The following is a description of a gene set: Genes containing one or more binding sites for (Nr2f2) in their promoter regions (TSS -1000,+100 bp) as identified by GTRD version 20.06 ChIP-seq harmonization. Mouse Gene Set: NR2F2_TARGET_GENES studied in species Mus musculus from publication Yevshin I, Sharipov R, Kolmykov S, Kondrakhin Y, Kolpakov F (PMID 30445619), and this is the list of marker genes: Ankrd39, 3110031N09Rik, Med16, Tmem259, Eprs1, Ascc2, Gm15722, Ak1 (NCBI Gene Id 59018), Qtrt2, 4921504E06Rik, Pum3, Phactr2, Ube2g2, Tnni3, Uck1, Arcn1, Desi1, Mtx3, Atf1, Manba, Mmgt2, Josd1, Zfp827, Dnajc19, Gm11483, Cep120, Hikeshi (NCBI Gene Id 67669), Upf3b, Hmgxb3, Ndufa2, Pex11g, Tbx3os1, Toe1, Socs5 (NCBI Gene Id 69052), Pspc1 (NCBI Gene Id 66645), Sdha, Zpr1, Podxl, Dennd4b, Six1, Tecrl, Ganab, Gm11214, Tti1, Adcy6, Smc5, Gm24016, Ccdc191, Mpc2, Pgm5 (phosphoglucomutase 5), Ccn2, Ogfrl1, Dusp28, Etfa, Alkbh7, Cluh, Baz1b, Ptp4a3, Xrcc6, Akt1s1, Zfp62, Hspe1, Susd6, Maip1, Prkce, Srp72, Rgl1, Elf4, Fhl1, Pphln1-ps1, Dtx4, Etohd2, 0610031O16Rik, Tor3a, Zfpm1, Tent2, Tmem198, Agps, 4930532G15Rik, Homer3 (NCBI Gene Id 26558), Zfand2a, Cenatac, Lrrc75a, Med23, Khk, Ccdc127, Chmp4b, Chd2, Mir3107, Cand1, Letmd1, Scoc, Eri3, Rsbn1l, Lrrc9, Zfp438 (NCBI Gene Id 77367), Nr2c1, Pcbp2, Tbc1d9b, Ywhag, Dcaf6, Kdm2a, Gtf2a2, 5330439K02Rik, Gbp8, D330023K18Rik, Slc48a1, Bfar, Sp2, Gmnn, Aup1, 1810041H14Rik, Pctp (phosphatidylcholine transfer protein), Ado, 6230400D17Rik, Arfgef2, Gpr107, Phactr4, Dnajc14 (DnaJ heat shock protein family (Hsp40) member C14), Prdm6, Gcc2, Vmac, Sema3a, Htra2, Pold3, Cfap97d1, Cyth1, Rprd1b, Rps3a1, Trabd, Taok3, Hspd1, Arl6ip6, Nipbl, Zfp768, Rpl27, Txlnb, Fhit, Mesd, Lrfn5 (leucine rich repeat and fibronectin type III domain containing 5), Scaf1, Dpp9, Adam19, Chic2, Adra2b, Cyb5r4, Tenm3, Ift46, Mylk3, Znrf1, Eef1b2, Nudt1, Smarcd2, Ing2, Unc13a, Wtap, Phf12, 1700025G04Rik, Ndufs1, Rpl11 (ribosomal protein L11), Rpl24, Gm4890, Tomm70a (NCBI Gene Id 70049), Chpf, Ktn1, Maml3, Plpp1, Smyd5, Iffo1, Gbp4, Prpf40a, Mvp, Mrpl11, Slc39a13, Pam16 (presequence translocase-asssociated motor 16), Por, Smarca5 (SWI/SNF related, matrix associated, actin dependent regulator of chromatin, subfamily a, member 5), Nol7, Ppat, Erp29, Ghr, Actc1, Cacna1c, Dedd, Fam193b, 1810059C17Rik, Atp5pb, Dusp3, Msrb3, Rragd, Ank3, Fdx2, Mrpl45, Prkg1, Zfp513, Mideas, Usp49, Gm20655, Gucy1a1, Samd4, Tmem164, Gspt1, Hif1an, Smad6, Mief1, Mir1945, Dhx35, Acbd3, 1700056E22Rik, Micos10, Hapln3, Casd1, Gbp9, Armc1, Zfp367, Mrps30, Ik (NCBI Gene Id 24010), Cnot2, Synpo, Tsku, Mmaa, Syt7, Chchd1, Wdr77, D630045J12Rik, Tyw5, Acad12, Klhl28, Rarres2, Arih2, Mmp16, Ndufs6, Gm24355 (NCBI Gene Id 115490472), Hibadh, Slain2, Shld1, 1810021B22Rik (RIKEN cDNA 1810021B22 gene), Napa (N-ethylmaleimide sensitive fusion protein attachment protein alpha), Ubac2, Rcan2, Tmem116, Isca1, Spg7, Foxp2, Zcchc7, Pcca, Gm12676, Thoc6, Mutyh, Pcbp1, Mir707, Fam13a, Ankrd1, Stk11, Guf1, Klhl35, Cox17, Togaram1, Mrm2, Glrx3, Med8 (NCBI Gene Id 80509), Timp3, Otulin, M6pr, Tbc1d17, Ggnbp2, Rps20, 1600020E01Rik, Snrpf (NCBI Gene Id 69878), Nr2c2, Mrpl16, Crtc2, Slc25a4, Rnf220, 4930505N22Rik, Ttn, Lzts2, Paics, Szt2, Tshz2